The following is a description of a gene set: Any neural crest cell migration that is involved in autonomic nervous system development. studied in species Mus musculus Mouse Gene Set: GOBP_NEURAL_CREST_CELL_MIGRATION_INVOLVED_IN_AUTONOMIC_NERVOUS_SYSTEM_DEVELOPMENT, and this is the list of marker genes: Fn1, Sema3f, Gdnf, Nrp1, Nrp2, Sema3a, Phox2b